Given this list of marker genes Ggta1, Mtdh, Met, Cimap2, Tlr2, Kras, here is a description of the gene set: from publication Motenko H, Neuhauser SB, O'Keefe M, Richardson JE (PMID 26092688) Mouse genes annotated to decreased lung tumor incidence (MP:0010267) retrieved from the Mouse Genome Informatics database via MouseMine Mouse Gene Set: MP_DECREASED_LUNG_TUMOR_INCIDENCE studied in species Mus musculus